The following is a description of a gene set: studied in species Mus musculus Any process that stops, prevents, or reduces the frequency, rate or extent of neuron differentiation. Mouse Gene Set: GOBP_NEGATIVE_REGULATION_OF_NEURON_DIFFERENTIATION, and this is the list of marker genes: Pax6, Cit, Foxg1, Cntn2, Notch3, Zhx2, Cntn4, Cntf, Bmp7, Fmr1, Rtn4, Rhoa, Tlx3, Apbb1, Meis1, Gdf11, Nkx6-3, Gli3, Eif4e, Isl1, Slc6a4, Eif4enif1, Shh, Lbx1, Phox2b, Hey1, Sox21, Fuom (NCBI Gene Id 69064), Fezf2, Hoxa2, Shoc2, Nepro, Hes1, Id4, Ttc3, Rap1gap, Lsm1, Sox3 (SRY (sex determining region Y)-box 3), Six3, Foxo3, Spag9, Ddx6, Fgfr3 (NCBI Gene Id 14184), Mag, Wnt3a, Pbx1, Zfp536, App, Isl2, Gsk3b, Disp3, Nkx2-2, Nbn, Dlx2, Jag1, Irx3, Ptbp1, Dtx1, Il1b, Calr, Sox2, Foxa2, Casz1, B2m, Hmg20a, Cav1, Aspm, Sox8 (NCBI Gene Id 20681), Eif2ak4, Med1, Mib1, Ascl1, Ptger3, Hes5 (hes family bHLH transcription factor 5), Notch1 (notch 1), Cdk5rap2, Gpr37l1, Dmd, Bex1, Dlx1, Nr2e1, Pou4f2, Trp73, Itgb1, Id2, Tunar, Ctdsp1, Rest (NCBI Gene Id 72127), Olig2, Dixdc1, Sox9, Dll1, Cd24a, Lmx1a